Given this list of marker genes ANKRD27, POLR3G, SNX8, USPL1, MIGA1, MDC1, PIGY, NUP50, MNT, ZNF708, CRTC3, PRMT6, PAGR1, SLC5A6, SLC36A4, ALDH6A1, FEZ2, LRRC45, G3BP1, KLHL20, TPD52L1, ZNF202 (zinc finger protein 202), CFAP69, B3GNT7, MYO19, KDM2B (NCBI Gene Id 84678), HTATSF1, XPA, YWHAB (tyrosine 3-monooxygenase/tryptophan 5-monooxygenase activation protein beta), NISCH, RLF, MFHAS1, FKBP15, TAF6, TSFM, RUVBL1, GPAM, ELP6, JUP, PPARGC1B, COMMD8, ZNF229, PDE7A, MARS2, RRP1B, HSD17B1, DDX21, PLPP6, ANGPTL4, TADA3, GRWD1, KRT10, DNAJB9 (NCBI Gene Id 4189), ATP6V1H, CPSF3, ARHGAP45, PPIE, CEP250, EXOC8, DAB2IP, NLRX1, TMEM62 (NCBI Gene Id 95722), CEP170B, KAT14, MTRR, IPO11, SLA2, ECSIT, CNNM2, SMIM7, ERMP1, CMKLR1, ZNF526, MRTO4, ZNF688, ETV5, TRMT10C, TSGA10, AGO2, ZMYM1, BDH1, PTGER4, SLC39A6, MAK16, PCDHB15, WIZ (NCBI Gene Id 58525), EBP, C2CD3, SLC35F6, HRAS, KLF4, DHODH, CTU1, PPOX, MRPS26 (NCBI Gene Id 81568), GTF2IRD1, ZYG11B, WTIP, NCBP3, RGS19 (regulator of G protein signaling 19), SLC25A51, ASXL1, FAM193B, SLC7A6, RIOX2, SEC11C, TSPAN6, C1orf131, TCHH, CAPN15, NFIC, CHD9 (NCBI Gene Id 80205, chromodomain helicase DNA binding protein 9), TTC4, DIP2A, AATF, TARBP2, PHETA2 (PH domain containing endocytic trafficking adaptor 2), USF2, ADCY9, ZNF655, P2RY2, WWC2, MOB3A, MAP7D1, IER3IP1, CMTR2, MEGF9, BRWD1, HMGB1, ZBED3, KIF1C, FANCF, GNL3, EHHADH, KIAA0930, IBTK, ZNF287 (NCBI Gene Id 57336), C19orf48P, CNKSR3, PHAX, TANGO6, PTPN9, ATF6B, SLF2, C7orf57, NUP155, HMG20B, FHOD1, MED16, SLC35E2B, FAM217B, MLH1, ZNF569, INSR, POR, OTULINL, COLEC11, KLF13, HNRNPLL, DNMT3L, OMA1, TM6SF1, MYO7A, SNAP23, IRF4, GCN1, ZNF14, STAC2, EIF5A2, DOC2B, GXYLT1, EXOC2, RNF187, CES3, MAST3, MTSS1, ARMCX4, CCPG1, PPP1R3D, N6AMT1, WDR24, SPSB3, LFNG, NRBF2, HNRNPA1, ITGA6 (NCBI Gene Id 3655), AKR1B15 (NCBI Gene Id 442622), NSMAF, SNHG8, ZNF367, DOLK, DNMT1, TNFAIP1, HELLS, PPP1R18, CDH5, SYS1, CELSR3, NUAK1, RIOX1, here is a description of the gene set: Human Gene Set: GSE22589_HIV_VS_HIV_AND_SIV_INFECTED_DC_DN Dendritic cells (DC) serve a key function in host defense, linking innate detection of microbes to the activation of pathogen-specific adaptive immune responses. Whether there is cell-intrinsic recognition of HIV-1 by host innate pattern-recognition receptors and subsequent coupling to antiviral T cell responses is not yet known. DC are largely resistant to infection with HIV-1, but facilitate infection of co-cultured T-helper cells through a process of trans-enhancement. We show here that, when DC resistance to infection is circumvented, HIV-1 induces DC maturation, an antiviral type I interferon response and activation of T cells. This innate response is dependent on the interaction of newly-synthesized HIV-1 capsid (CA) with cellular cyclophilin A (CypA) and the subsequent activation of the transcription factor IRF3. Because the peptidyl-prolyl isomerase CypA also interacts with CA to promote HIV-1 infectivity, our results suggest that CA conformation has evolved under opposing selective pressures for infectivity versus furtiveness. Thus, a cell intrinsic sensor for HIV-1 exists in DC and mediates an antiviral immune response, but it is not typically engaged due to absence of DC infection. The virulence of HIV-1 may be related to evasion of this response, whose manipulation may be necessary to generate an effective HIV-1 vaccine. Genes down-regulated in monocyte-derived dendritic cells infected by: HIV versus HIV and SIV. from publication Manel N, Hogstad B, Wang Y, Levy DE, Unutmaz D, Littman DR (PMID 20829794) studied in species Homo sapiens